Given this list of marker genes IGSF6, RUNX3, CREB3L2, NRROS (negative regulator of reactive oxygen species), KCNE3, ITGB2, STAT5A, LOXL3, LHFPL2, CYTL1, DPYD, IL10RA, RNASE6, NCF2, ELF4, HCLS1 (hematopoietic cell-specific Lyn substrate 1), SLC7A7, IL13RA1, GAPT, IL18, PLEK, TGFBR1, NCKAP1L, ABCC4, ITGAX, PPP1R18, LYL1, RBM47, FKBP15, HLX, RGS1, C3, CXCL16, ZFP36L2, LGALS9C (NCBI Gene Id 654346), CD84, TNFRSF1B, BIN2, C1QC, SH2B3, ADAP2, PYCARD, SAMSN1, MAF, NPC2, TMEM106A, SLC1A5, GAL3ST4, TYROBP, CD4, SPP1, SFT2D2, ITGAM, GPX1, TCIRG1, APBB1IP, RPS6KA1, CAPG, CD37, GIMAP2, here is a description of the gene set: studied in species Homo sapiens TYROBP causal network in microglia Human Gene Set: WP_TYROBP_CAUSAL_NETWORK_IN_MICROGLIA